The following is a description of a gene set: Human Gene Set: GSE2706_UNSTIM_VS_8H_R848_DC_UP Toll like receptors (TLRs) sense microbial products and initiate adaptive immune responses by activating dendritic cells (DCs). Since pathogens may contain several agonists we asked whether different TLRs may synergize in DC activation. We report that in human and mouse DC TLR3 or TLR4 potently synergize with TLR7, TLR8 or TLR9 in the induction of selected cytokine genes. Upon synergistic stimulation, IL-12, IL-23 and Delta-4 are induced at levels 50-100 fold higher than those induced by optimal concentrations of single agonists, leading to enhanced and sustained TH1 polarizing capacity. Using microarray analysis we show that only 1.5% of the transcripts induced by single TLR agonists are synergistically regulated by combinations of TLR4 and TLR8 agonists. These results identify a combinatorial code by which DCs discriminate pathogens and provide (suggest) a rationale to design adjuvants for TH1 responses. Series_overall_design: 3 untreated, 3 treated with LPS at 2h, 3 treated with LPS at 8h, 3 treated with R848 at 2h, 3 treated with R848 at 8h, 3 treated with LPS + R848 at 2h, 3 treated with LPS + R848 at 8h Genes up-regulated in comparison of unstimulated dendritic cells (DC) at 0 h versus DCs stimulated with R848 for 8 h. from publication Napolitani G, Rinaldi A, Bertoni F, Sallusto F, Lanzavecchia A (PMID 15995707) studied in species Homo sapiens, and this is the list of marker genes: SLC35C1, DNM3OS, ZNF850, ANO2, CST9, RGS9BP, UROS, NFIA, CARS2, PTAFR, CDNF, ACP5, GPBAR1, H3C11, P4HA2, ZNF248, TMEM205, EMP1, SPATA2, DAAM1, FRAT2, ITGB5, CNBD2, DNAL4, ZNF324 (NCBI Gene Id 64287), ACTL9, CDCA7L, CROCCP3, GALNT10, ZAR1, CCDC9B, CREB5, SCARB1, CYP1B1 (cytochrome P450 family 1 subfamily B member 1), PRAM1, GZMM, C1RL, MAML3, WFS1, TSHZ1, STX10, VPS37A, BLVRB, AURKC, HSPG2, CBX7, PIK3IP1, HTR1A, SH3RF3, ASGR2, CHST13, FABP1, SLC25A48, DAB2, ICAM2, ANKRD20A11P (NCBI Gene Id 391267), ACCS, SIGIRR, VEGFB, ACAT1, CAPRIN2, FXYD5, ALDH7A1, PLD1, ERP29, LY86 (lymphocyte antigen 86), PHF19, PDK3, LINC02297, FAM20C, CCNE1, CLUAP1 (NCBI Gene Id 79851), NUDT16L1, CLEC3B (C-type lectin domain family 3 member B), KIAA0513, NAA38, YIF1B, MNS1, NMNAT3, PECAM1, ENOSF1, TSPAN4, TRPS1, DUOX1, TGFBI, PYGL, P2RY11, SH3BGR, NUCB2, MIR646HG, TRAM2, SLC22A5, MFSD12, FES, FAM174C, SHB, ABHD14A, MEAK7, ZCCHC24, PRRT3, GPR20, XYLT1, BIN3, B3GLCT (NCBI Gene Id 145173), MBP, ZFP36L2 (ZFP36 ring finger protein like 2), GRHPR, MAGED2, CHID1, EIF3LP3, PEX5, NFE2, AVPI1 (NCBI Gene Id 60370), SNRNP25, TBXAS1, ABAT, TIE1, MARVELD1, SLC19A1, TMEM117, FOXQ1, PJVK, WDR87, ESYT1, HEXA, A4GNT, SIVA1, EBPL, SLC16A6, LY9, SLC22A18, FDXR, DCXR, GFRA2, RPL39L, TREM2, HSD3B7, SH2D3C, SLC22A18AS, KLF4, PRSS36, PSRC1, IL17RA (NCBI Gene Id 23765), TSHZ3, C16orf54, LINC03124, TRIM47, TPCN1, PLBD1, TMEM191A, WDFY2, MAP3K5, AMDHD2, CRTAP, FOXB1, ZNF169, ACP6, LINC00342, CLMN, FHL1, SUFU, SLC39A3, EVA1B, ABCB11, RASSF1, DFFB (NCBI Gene Id 1677), LIN28A, C18orf15, ATP6V0E2, LGI4, DDB2, ALG1, PIK3C2B, FAM230C, GAS2L3, IL16, DIP2A, ERLEC1P1 (NCBI Gene Id 100292863), CPVL, CNRIP1, DPEP2, CDR2-DT, FAM210B, DTD2, SCRN2, OSBPL1A, PTGFRN, NUDT16, GFOD1, ANKRD54, MAN2B2, PTGS1, CCKAR, PGAP3, MAOB, HRH1, MPST, DBP